The following is a description of a gene set: species: Mus musculus Transcriptional and post-translational regulation of MITF-M expression and activity Mouse Gene Set: REACTOME_TRANSCRIPTIONAL_AND_POST_TRANSLATIONAL_REGULATION_OF_MITF_M_EXPRESSION_AND_ACTIVITY, and this is the list of marker genes: Mars1, Ep300, Dars1 (aspartyl-tRNA synthetase 1), Lars1, Csf1, Aimp2, Akt3, Mitf, Gsk3b, Eprs1, Xpo1, Sumo1, Mark3, Iars1, Rps6ka1, Sirt1, Sox10, Kitl, Tbx3, Rars1, Wnt3a, Mapk1, Qars1, Eef1e1, Hint1, Kars1, Aimp1, Mapk3, Ube2i, Kit (KIT proto-oncogene receptor tyrosine kinase), Tnfsf11